The following is a description of a gene set: Binding to an alkali metal ion; alkali metals are those elements in group Ia of the periodic table, with the exception of hydrogen. species: Homo sapiens Human Gene Set: GOMF_ALKALI_METAL_ION_BINDING, and this is the list of marker genes: HDAC4, ATP1A1, PKM, CPS1, KCNA4, IMPA1 (inositol monophosphatase 1), ATP4A, SLC34A2, DRG1, ADPRH, SCN8A, TDG, CAPN3, AMELX, ACAT1, KCNJ11 (NCBI Gene Id 3767), PKLR (NCBI Gene Id 5313), ATP1A2, PDXK, SLC6A4